Given this list of marker genes P2rx4, Cacnb3, Rab3a, Tmem87a, Kcna1, Kcnk4, Kcnk2, Tshz3, here is a description of the gene set: studied in species Mus musculus Mouse Gene Set: GOBP_SENSORY_PERCEPTION_OF_TOUCH The series of events required for an organism to receive a touch stimulus, convert it to a molecular signal, and recognize and characterize the signal. This is a neurological process. The perception of touch in animals is mediated by mechanoreceptors in the skin and mucous membranes and is the sense by which contact with objects gives evidence as to certain of their qualities. Different types of touch can be perceived (for example, light, coarse, pressure and tickling) and the stimulus may be external or internal (e.g. the feeling of a full stomach).